The following is a description of a gene set: Expression microarray analysis identified over genes regulated during puberty in the mouse mammary gland. Most prominent were genes whose expression increased in parallel with pubertal development and remained high thereafter. Members of the Wnt, transforming growth factor-beta and oestrogen-signalling pathways were significantly overrepresented. Comparison to expression data from CITED1 knockout mice identified a subset of oestrogen-responsive genes displaying altered expression in the absence of CITED1. Included in this subset are stanniocalcin2 (Stc2) and amphiregulin (Areg). Chromatin immunoprecipitation revealed that ERalpha binds to oestrogen response elements in both the Stc2 and Areg genes in the mammary gland during puberty. Additionally, CITED1 and ERalpha localize to the same epithelial cells of the pubertal mammary gland, supporting a role for interaction of these two proteins during normal development. In a human breast cancer data set, expression of Stc2, Areg and CITED1 parallel that of ERalpha. Similar to ERalpha, CITED1 expression correlates with good outcome in breast cancer, implying that potential maintenance of the ERalpha-CITED1 co-regulated signalling pathway in breast tumours can indicate good prognosis. from publication McBryan J, Howlin J, Kenny PA, Shioda T, Martin F (PMID 17486082) Genes down-regulated during pubertal mammary gland development between weeks 3 and 4. Human Gene Set: MCBRYAN_PUBERTAL_BREAST_3_4WK_DN studied in species Mus musculus, and this is the list of marker genes: MMD2, PRKAG2, CTH, RPL36A, TRAC, ANXA8L1, IGHM, NFIA, PLP1, PAM, CDKN1A, CAP1, RPS10, FABP3 (fatty acid binding protein 3), PHGDH, COX7A1, WFDC21P, TXNDC16, REEP6, ALAS1, NFKB2, RGS2, ZBTB16, ICE1, NNAT, MBP, IFI16, LILRA4, COQ8A, IGFBP3, JPT1, RIPOR2, TRBC2, IDH1, HP, NDUFV2, TIMP4, NRIP1, BCL6, LCK, TCF7 (NCBI Gene Id 6932), RPL14